The following is a description of a gene set: species: Homo sapiens Human Gene Set: CUI_DEVELOPING_HEART_C9_B_T_CELL from publication Cui Y, Zheng Y, Liu X, Yan L, Fan X, Yong J, Hu Y, Dong J, Li Q, Wu X, Gao S, Li J, Wen L, Qiao J, Tang F (PMID 30759401), and this is the list of marker genes: CLK1, HLA-B, CTSW, CORO1A, LTB, HLA-F, HLA-H, GPR65, CCND3, LITAF, CYTIP, LPXN, ISG20, CD69, COTL1, PIM2, PABPC1, PTPRC, IL2RB (interleukin 2 receptor subunit beta), SEPTIN1, RGS1, SH3KBP1, WIPF1, SLC2A3, SARAF, PTPN22, LIMD2, STK4, CYRIB, IFITM1 (NCBI Gene Id 8519), RUNX3, IFITM2, PLAC8, IL16, SKAP1, PIP4K2A, LAPTM5, GPSM3, IL32, TCF7, ITK, PLAAT4, LSP1, NFKBIA, GNG2, ARHGAP9, CD3D, CCL5, DENND2D (DENN domain containing 2D), CNOT6L, DUSP2, PRKCH, FCER1G, PVRIG, IL7R, CST7 (cystatin F), DEDD2, TNFAIP3, CDC42SE2, ZNF331, JUNB, GZMA, ITGB2, SAMSN1, ZAP70, ACAP1, CD37, ARPC1B, CD52, TXK, ISG15, RNF166, DNAJB1, BIN2, PIK3IP1, SELL, CLEC2D, HLA-C, ARL4C, ZFP36L2, CLEC2B, RHOH, ADGRE5, IL2RG, ETS1, HCST, GPR183, UCP2, SEPTIN6, CD48, TXNIP, SASH3, KLRB1, LINC00861, CD247, CD3G, CD53, TMC8, NKG7, PDCD4 (programmed cell death 4), LAT (NCBI Gene Id 27040), LCP1, FYB1, ZFP36, PSMB9, ARHGDIB, CD3E, EVL, CD7, ARHGAP15, FXYD5, FAM107B, TAPBP, SATB1, ARHGAP45, SAMD3, TBC1D10C, RAC2, RGCC, OSTF1, TAGAP, GIMAP4, TUBA4A, PTGER4, HLA-A, FCMR, SRGN, CD96 (NCBI Gene Id 337949), SPOCK2, IRF1 (NCBI Gene Id 96501), ELF1, HLA-E, BTG1, GIMAP7, TMIGD2, HCLS1, ITGAL, GMFG, NHERF1, RNF213, SH2D1A, LEPROTL1, LEF1, TSC22D3, PRF1, STK17B, KLRD1, ARHGEF1, PTPRCAP, YPEL5, JAK1, CXCR4, CD44, LCK, RIPOR2